The following is a description of a gene set: An increased concentration of dicarboxylic acid in the urine. Dicarboxylic aciduria studied in species Homo sapiens Human Gene Set: HP_DICARBOXYLIC_ACIDURIA, and this is the list of marker genes: ACAD8, TRMU, ALDH6A1, MRPL39, SLC22A5 (solute carrier family 22 member 5), MMAB, HPD, ACSF3, CPT1A, NDUFS4, CPOX, TAMM41, ABCD4, ACAD9, SLC25A20, MTR, SFXN4, LETM1, DHTKD1, PEX14, L2HGDH, ETHE1, TCN2, ETFB, MCEE, ACADS, MMAA, CD320, MMADHC, FDFT1, MTRR, CA5A, GCDH, MMACHC, SUGCT, ETFDH, SUCLA2, NFU1, IDH1, FBXL4, GATA1 (GATA binding protein 1), IDH2 (isocitrate dehydrogenase (NADP(+)) 2), SCO1, COQ4, SUCLG1, ACADM, CPT2, COX16 (NCBI Gene Id 51241), SLC13A3 (solute carrier family 13 member 3), POLG, PRDX1 (NCBI Gene Id 5052), HCFC1, FTCD, MMUT, MLYCD, PPOX, HMBS, HADH, SLC52A1, D2HGDH (NCBI Gene Id 728294), ETFA, HSPD1, ACADVL, UROS, HMGCL, LMBRD1 (NCBI Gene Id 55788), FH, SLC25A1, HMGCS2 (NCBI Gene Id 3158), ALAD